The following is a description of a gene set: Any process that stops, prevents or reduces the frequency, rate or extent of potassium ion transmembrane transporter activity. Human Gene Set: GOBP_NEGATIVE_REGULATION_OF_POTASSIUM_ION_TRANSMEMBRANE_TRANSPORTER_ACTIVITY species: Homo sapiens, and this is the list of marker genes: SUMO1, KCNQ1, KCNAB1, GRP, KCNE1, KCNE2, KCNE3, ANK3, KCNRG